Given this list of marker genes FOS, SSX1, PLA2G6, SPANXC, CLU (clusterin), GADD45B, LGALS1, MMP12, GAGE12G, FOSL2, STXBP6, ANXA1, NTS, CGA, PPP1R15A, TEX14, HSPA1A, ATF3, SNAI1, H2BC8, SPANXA1, GAGE12F, HSPB8, H2AC18, ARC, DHRS2, here is a description of the gene set: Top genes up-regulated in HEK293 cells (fibroblast) in response to trichostatin A (TSA). A hallmark of vertebrate genes is that actively transcribed genes are hypomethylated in critical regulatory sequences. However, the mechanisms that link gene transcription and DNA hypomethylation are unclear. Using a trichostatin A (TSA)-induced replication-independent demethylation assay with HEK 293 cells, we show that RNA transcription is required for DNA demethylation. Histone acetylation precedes but is not sufficient to trigger DNA demethylation. Following histone acetylation, RNA polymerase II (RNAP II) interacts with the methylated promoter. Inhibition of RNAP II transcription with actinomycin D, alpha-amanitin, or CDK7-specific small interfering RNA inhibits DNA demethylation. H3 trimethyl lysine 4 methylation, a marker of actively transcribed genes, was associated with the cytomegalovirus promoter only after demethylation. TSA-induced demethylation of the endogenous cancer testis gene GAGE follows a similar sequence of events and is dependent on RNA transcription as well. These data suggest that DNA demethylation follows rather than precedes early transcription and point towards a novel function for DNA demethylation as a memory of actively transcribed genes. from publication D'Alessio AC, Weaver IC, Szyf M (PMID 17709385) studied in species Homo sapiens Human Gene Set: DALESSIO_TSA_RESPONSE